Given this list of marker genes BOC, RHOB, ARID5B, RBM41, MYLIP, ATP2B1-AS1, CD59, SPTAN1, ATOSB, DLX1, BAIAP2, FBXL20, TENM2, SHISA2, NFIA, AP5Z1, VIM, VCL, SPSB3, MB21D2, MXD4, TP53INP1, KIF26B, RBMS3, MSRB2, CYP20A1, MAN2B2, GNAI1, MLC1, ZNF436, H2AC18, KCNMB4, DOK4, H2BC21, SMAD6, SAT1, ATG2A, MARCKS, AKR1C3, GAB2, LSP1P5, TUFT1, MVP, LINC00963, MAP1LC3B, DOK5, SLC20A2, CST3, LPAR6, FOXC1, MMP24OS, RILPL2, MAP1LC3A, CLIP3, PIK3R2, HBP1, YPEL2, SECISBP2L, PLEKHJ1, TRIM38, ABAT, LIMA1, TANC2, TSHZ1, TFPI, H3C10, CAMK2D, ZCCHC24, BLCAP, PSAP, S100A10, TSPYL2, DLX2, HLA-E, TAGLN, YPEL3, HES1, SATB1, LZTS3, CARD6, ATOH8, C1orf54, BCL9L, RORB, TGFB2, TCF7L2, CYP26B1, COL5A1, LTBP3, CCN1, PCDH18, PTH1R, KLHL41, IGFBP7, CDC42EP4, EFNA1, COLEC12, ENPP2, H2AC6, LMNA, CLEC2B, SIDT2, GSN, MTURN, LNPEP, ING4, G6PC3, DAPL1, SMOX, MFSD6, SEZ6L2, AJUBA, DDAH1, OSR2, TMSB4X, AMOTL2, AMIGO2, PID1, FZD1, STAT2, GEM, CREB3L1, PDP1, IL17RD, ATP2B1, TSPYL4, ADAMTS5 (ADAM metallopeptidase with thrombospondin type 1 motif 5), THBS3, PHLDB1, ANGPTL2, NEU1, ITM2C, CYTH2, FRMD6, AAMDC, SGSH, ZNF804A, BTG1, OXR1, PDCD4, MAP2 (microtubule associated protein 2), LOX, WIPI2, HMCN1, VGLL4, SLC35C2, RETREG2, SEPTIN6 (septin 6), MALAT1, ARHGAP29, LMO3, TMEM184C, SPARCL1, GMPPA, RGS5, MGP, C11orf96, A2M, MIR1245A, LGALS3BP, DST, PAPSS2, RNF150, ZYX, TRIM73, NT5E, CHPF, POSTN, QSOX1, DPP7, PTX3, LRRC17, CCDC80, CEP164, DACT3, CTSD, HOXB13, MIR214, DSEL, FRMD4A, KLF7, SIPA1L2, MXD1, EBF1, BOD1L1, ANKRD6, FKBP9, DISP1, COL7A1, TOX, SULF2, MXRA8, PXDC1, TGFBR3, MYOM1, PPP1R9A, DAB2, IER5L, EMCN (endomucin), TP53INP2, IGF2BP2, COL5A2 (NCBI Gene Id 1290), NPC2, TGFBR2, DKK1, EPHA3 (EPH receptor A3), ALDH1A1, C4orf3, ANGPT1, ELP2, SLFN5, NUDT17, NCOR2, ZFYVE1, EYA1, PLG, GRN, NBL1, NYNRIN, IGDCC4 (immunoglobulin superfamily DCC subclass member 4), GNAS, FOXN3, TRO, MKNK2, FMNL2, GOLGA2, PARVA, FN1, COL1A1, UBE2H, HDAC5, CCS, LINC02986, IGFBPL1, FSTL1, CRYBG3, ZBTB43, SNAPC4, LINC02593, SOX4, SELENOP, MAGED4B, TENT5A, TUBA4B, DLC1, RHOBTB1, LMO2, NUAK1, TRAK1, PBXIP1, MIRLET7BHG, FLNB, TBC1D22A, RPRM, SPHK1, MLLT3, TECPR1, INAFM2, PRND, IGFBP5, KLF2, NAP1L1, MEF2C, TMEM150A, IER3, JAKMIP2, CDON, LAMB2, ECE1, SRGAP1, TMEM129, LRRN3, NLRP1 (NLR family pyrin domain containing 1), MYL5, SELENBP1, PLAU, GULP1, CCN3, HEXA, KIAA1217, ZNF827, METRNL, IL13RA1, MAP2K5, LAMA4, DR1, AKR1C1, CSRNP1, LRP10, ADM, GNS, NICOL1, ISG15, DCLK1, FBN1, TNRC6B (trinucleotide repeat containing adaptor 6B), PRSS23, LIMCH1, LRRFIP1, LMO7, SLC38A7, SLC40A1, RIN2, LAMC1, COL3A1, GJA3, RGS3, ORAI3, FOXO1, MAN2A1, CRABP1, SPARC, UBXN4, AFF1, NFKBIZ, LDOC1, SRRM2, ZNF423, MEF2D, MSH3, FAM131B-AS2, TIMP2, YIPF2, TNC, XKR4, IL11RA, H2AC25, MFSD10, SLC35D2, KLHDC8B, FAT3, GPNMB, KLHL24, MAGED1, FNDC3B, SLC26A7, ORAI2, here is a description of the gene set: from publication Kinsey M, Smith R, Lessnick SL (PMID 17114343) Human Gene Set: KINSEY_TARGETS_OF_EWSR1_FLII_FUSION_DN studied in species Homo sapiens Genes down-regulated in TC71 and EWS502 cells (Ewing's sarcoma) by EWSR1-FLI1 as inferred from RNAi knockdown of this fusion protein. A number of solid tumors, such as alveolar rhabdomyosarcoma, synovial sarcoma, and myxoid liposarcoma, are associated with recurrent translocation events that encode fusion proteins. Ewing's sarcoma is a pediatric tumor that serves as a prototype for this tumor class. Ewing's sarcomas usually harbor the (11;22)(q24;q12) translocation. The t(11;22) encodes the EWS/FLI fusion oncoprotein. EWS/FLI functions as an aberrant transcription factor, but the key target genes that are involved in oncogenesis are largely unknown. Although some target genes have been defined, many of these have been identified in heterologous model systems with uncertain relevance to the human disease. To understand the function of EWS/FLI and its targets in a more clinically relevant system, we used retroviral-mediated RNAi to knock-down the fusion protein in patient-derived Ewing's sarcoma cell lines. By combining transcriptional profiling data from three of these lines, we identified a conserved transcriptional response to EWS/FLI. The gene that was most reproducibly up-regulated by EWS/FLI was NR0B1. NR0B1 is a developmentally important orphan nuclear receptor with no previously defined role in oncogenesis. We validated NR0B1 as an EWS/FLI-dysregulated gene and confirmed its expression in primary human tumor samples. Functional studies revealed that ongoing NR0B1 expression is required for the transformed phenotype of Ewing's sarcoma. These studies define a new role for NR0B1 in oncogenic transformation and emphasize the utility of analyzing the function of EWS/FLI in Ewing's sarcoma cells.